The following is a description of a gene set: Catalysis of the reaction: a cytidine in tRNA + S-adenosyl-L-methionine = a 5-methylcytidine in tRNA + S-adenosyl-L-homocysteine + H+. This modification can occur on seversal residues, including cytidine(34), cytidine(40), cytidine(48), and cytidine(49). Mouse Gene Set: GOMF_TRNA_CYTIDINE_5_METHYLTRANSFERASE_ACTIVITY species: Mus musculus, and this is the list of marker genes: Nsun2, Nsun3, Nsun4, Trdmt1, Nsun6 (NOL1/NOP2/Sun domain family member 6)